Given this list of marker genes RRM2 (ribonucleotide reductase regulatory subunit M2), RBKS, NBAS, GRHL1, MRPL33, KLF11, SUPT7L (SPT7 like, STAGA complex subunit gamma), LRATD1, FNDC4, NTSR2, NOL10, LPIN1, MYCNOS, SNTG2, GPN1, WDR43, MYCN, HPCAL1, TPO, SNTG2-AS1, CYRIA, IFT172, KCNF1, YPEL5, TRIB2, FOSL2, ODC1-DT, ENSG00000228496, ODC1, PLB1, ALK, TAF1B, GREB1, PDIA6, CLIP4, ZNF512, CCDC121, TRMT61B, SLC4A1AP, DDX1, SLC66A3, PPP1CB-DT, ROCK2 (NCBI Gene Id 9475, Rho associated coiled-coil containing protein kinase 2), here is a description of the gene set: Identifying genes, whose expression is consistently altered by chromosomal gains or losses, is an important step in defining genes of biological relevance in a wide variety of tumour types. However, additional criteria are needed to discriminate further among the large number of candidate genes identified. This is particularly true for neuroblastoma, where multiple genomic copy number changes of proven prognostic value exist. We have used Affymetrix microarrays and a combination of fluorescent in situ hybridization and single nucleotide polymorphism (SNP) microarrays to establish expression profiles and delineate copy number alterations in 30 primary neuroblastomas. Correlation of microarray data with patient survival and analysis of expression within rodent neuroblastoma cell lines were then used to define further genes likely to be involved in the disease process. Using this approach, we identify >genes within eight recurrent genomic alterations (loss of 1p, 3p, 4p, 10q and 11q, 2p gain, 17q gain, and the MYCN amplicon) whose expression is consistently altered by copy number change. Of these, 84 correlate with patient survival, with the minimal regions of 17q gain and 4p loss being enriched significantly for such genes. These include genes involved in RNA and DNA metabolism, and apoptosis. Orthologues of all but one of these genes on 17q are overexpressed in rodent neuroblastoma cell lines. A significant excess of SNPs whose copy number correlates with survival is also observed on proximal 4p in stage 4 tumours, and we find that deletion of 4p is associated with improved outcome in an extended cohort of tumours. These results define the major impact of genomic copy number alterations upon transcription within neuroblastoma, and highlight genes on distal 17q and proximal 4p for downstream analyses. They also suggest that integration of discriminators, such as survival and comparative gene expression, with microarray data may be useful in the identification of critical genes within regions of loss or gain in many human cancers. species: Homo sapiens from publication Łastowska M, Viprey V, Santibanez-Koref M, Wappler I, Peters H, Cullinane C, Roberts P, Hall AG, Tweddle DA, Pearson AD, Lewis I, Burchill SA, Jackson MS (PMID 17533364) Genes co-amplified within MYCN in primary neuroblastoma tumors. Human Gene Set: LASTOWSKA_COAMPLIFIED_WITH_MYCN